The following is a description of a gene set: Chondrosarcoma studied in species Homo sapiens Human Gene Set: HP_CHONDROSARCOMA A slowly growing malignant neoplasm derived from cartilage cells., and this is the list of marker genes: PTH1R, TAF15, EXT2, IDH1, EXT1, NR4A3, IDH2